Given this list of marker genes DLX1, AFF4, CAPN3, RGS4, SATB2, MEF2C, PAX2, ASXL1, FEM1C, MMP25, ZNF146, RNF11, VPS54, XKR6, NFIB, PARD3B, CNIH1, VHLL, CACNA1G, SET, DACH1, SRSF3, PTGES2, TM2D1, GRB2, RASAL2, FGF7P6, TRNP1, MMP19, SMARCA2, CSTF3, SGMS1, BDNF, CABLES1, ZDHHC1, EYA4, UTS2, FBXL3, MYLK, SEPTIN7, here is a description of the gene set: Genes having at least one occurence of the motif CTCTATG in their 3' untranslated region. The motif represents putative target (that is, seed match) of human mature miRNA hsa-miR-368 (v7.1 miRBase). Human Gene Set: CTCTATG_MIR368 species: Homo sapiens